Given this list of marker genes Syncrip, Rpl13a, Gapdhrt2, Gapdh, Gapdh-ps15, Gapdhrt, Eprs1, here is a description of the gene set: A protein complex which mediates interferon-gamma-induced transcript-selective translation inhibition in inflammation processes. The complex binds to stem loop-containing GAIT elements in the 3'-UTR of diverse inflammatory mRNAs and suppresses their translation by blocking the recruitment of the 43S ribosomal complex to m7G cap-bound eIF4G. In humans it includes RPL13A, EPRS, SYNCRIP and GAPDH; mouse complexes lack SYNCRIP. Mouse Gene Set: GOCC_GAIT_COMPLEX studied in species Mus musculus